The following is a description of a gene set: Genes predicted to be targets of miRBase v22 microRNA hsa-miR-652-3p in miRDB v6.0 with MirTarget v4 prediction scores > 80 (high confidence targets). species: Homo sapiens Human Gene Set: MIR652_3P from publication Chen Y, Wang X (PMID 31504780), and this is the list of marker genes: UGT2B4, CSAG1, TNRC6A, KCTD10, ISL1